The following is a description of a gene set: studied in species Homo sapiens Mesenchymal 2 Human Gene Set: HE_LIM_SUN_FETAL_LUNG_C0_MESENCHYMAL_2_CELL from publication He P, Lim K, Sun D, Pett JP, Jeng Q, Polanski K, Dong Z, Bolt L, Richardson L, Mamanova L, Dabrowska M, Wilbrey-Clark A, Madissoon E, Tuong ZK, Dann E, Suo C, Goh I, Yoshida M, Nikolić MZ, Janes SM, He X, Barker RA, Teichmann SA, Marioni JC, Meyer KB, Rawlins EL (PMID 36493756), and this is the list of marker genes: PTTG1, SLC2A13, TES, PAG1, COL23A1 (NCBI Gene Id 91522), ECT2, ATAD5, LMNB2, FBXO5, MEIS2 (NCBI Gene Id 56908), ASF1B, NDC80, H1-1, MCM4, KIF18A, H2AC13, CLSPN, CKAP2L (cytoskeleton associated protein 2 like), FAM83D, CDK1, SPAG5, CD24, RMI2, MID1, SYK, FOXF2, DHX57, THNSL2, LMNB1, H2AC11, THSD4, CRABP2, CCDC74A, CISD1, TRIB2, CIP2A, GINS2, CDCA2, MND1, H2AC14 (NCBI Gene Id 8331), TPX2, INPP5F, DTNB, FENDRR, EPS8, SGO1, PDXP, CYTH3 (cytohesin 3), MSRA, LRIG3, EYA2, PIM1 (Pim-1 proto-oncogene, serine/threonine kinase), SKA3, PDLIM4, CIB2, GPR161, C12orf75, REEP3, ARHGAP33, BUB1, H4C11, CDKN3, B3GALNT2, OAF, KNL1, TWIST2, H2BC21 (NCBI Gene Id 8349), EZH2, TMEM176B, H1-5, BIRC5, TNFRSF21, DLGAP5, CCNA2, PDE3A (phosphodiesterase 3A), GPSM3 (G protein signaling modulator 3), UBE2S, KIF20A, RGMA, CDC45, GRIK2, PEG3, NKAIN3, UBE2C, CENPE, TROAP, HAPLN1, PIMREG, FST, IQGAP2, NCAPH, MAD2L1, NEIL3, TRIOBP, ANKS1A, CHST9, IGFBP2, MOB3B, DSN1, EVA1A, ZNF804A, MKI67, FLNB, TMEM176A, SGO2, PDE1A (NCBI Gene Id 5136), MID1IP1, NUSAP1, SPC24 (SPC24 component of NDC80 kinetochore complex), PTCH2, TK1, TMEFF1, KIF26B, CENPF, DEPDC1B, AMOTL2, TNFAIP6, ARHGAP11A, FBN2, HSPA12A, HJURP, OIP5, TOX, POC1A (POC1 centriolar protein A), COLEC11, SULF1, CDC20, PITX2 (paired like homeodomain 2), LDLR, EPHA4, C8orf34, KIF23, VOPP1, PRKAR2B, CENPA, SGK1, TPBG, SLC8A1, BRCA2, ANLN, ZWINT, RARB, EMC9, HOXA4, CAPN5 (NCBI Gene Id 7445), NSG1 (neuronal vesicle trafficking associated 1), BMP7, SLC25A33, HMGN5, AURKB, ZNF93, FRZB, KNSTRN, FLRT3, CENPM, PBK, TACC3, DLG2, IL17D, GPC4, SPIN2A, KIF18B, EPB41, PCDH17, ANPEP, MCM10, FZR1, NTF3, CKAP2, GPR37, NTM, MIR99AHG, SPC25, RHBDD2, CENPP, ITGB8, DBF4 (DBF4-CDC7 kinase regulatory subunit), DCLRE1B, LINC01082, HNRNPA1L3, DEPDC1, BICD1, SH3BP5, EFEMP1, H4C12, CENPN, NETO2, DIAPH3, TWIST1, MSC-AS1, TMEM65 (transmembrane protein 65), CDCA5, RAD51AP1 (RAD51 associated protein 1), ISL2, CDC25C, H3C2, CXXC4, C21orf58, AURKA, PXK, KIF22, CLMP, ITPRID2 (ITPR interacting domain containing 2), TUBB2B, KIF11, ADAMTS19, KIFC1, H2AC16, LINC02381, BUB1B, KPNA2, PAWR, FOXM1, TRIP13, SIPA1L2, KIF15, EFNB2, SHISA3, CCNB2, TRIO, TRAIP, GTSE1, FZD2, GTF2IRD1, RHNO1, CENPL, HELLS, FANCI, FHL2, ASPM, LRR1, MAPK10, H2BC9, NEURL1B, CDCA3, CDCA8, NUF2, UHRF1, CENPU, CCDC74B, DKKL1, FGF13, RGS10, NUDT14, AEBP2, B3GALT6, LEF1, KIF2C, PRC1, METTL25, ESCO2, HHIP-AS1, TMTC2, HMGA2 (high mobility group AT-hook 2), HSD17B14, JAZF1, KIF4A, RACGAP1, RALGPS2, NCAPG, HHIP, KIAA1958, NKX6-1 (NK6 homeobox 1), DNAJC12 (NCBI Gene Id 56521), FOXP2, PHLDB2, SERINC2, PITX1, ITGA4, PROM1, CCNB1, OLFML2B, LATS2, PDLIM3, XIST, SYNPO2, PGP, PLK1, UBE2T, STARD4, CNTN4, MYBL2, PKMYT1, MXD3, H2AC25, METTL21A, KIF14, CTHRC1, DPP10, MELK (NCBI Gene Id 9833), LDB2, NCAM1, OSR2, CNTNAP3B, CENPO, MSC, ZFHX4, KLHL5, FANCA, TOP2A